Given this list of marker genes Gna13, Gnb3, Gng10, Gnai2, Gng7, Mapk14, Gnb4, Gnai3, Gnb1, Gna11, Tbxa2r, Src, Gng2, Gnaq, Gna15, Gnb2, Gng4, Pla2g4a, Gng3, Gnai1, Gngt2, Gnb5, Gng11, Gng5, Aamp, Gng8, Gna14, P2ry12, P2ry1, Gnat3, Gngt1, Gng12, Gng13, here is a description of the gene set: species: Mus musculus Mouse Gene Set: REACTOME_SIGNAL_AMPLIFICATION Signal amplification